The following is a description of a gene set: studied in species Homo sapiens Human Gene Set: GOBP_CARDIAC_CHAMBER_MORPHOGENESIS The process in which a cardiac chamber is generated and organized. A cardiac chamber is an enclosed cavity within the heart., and this is the list of marker genes: MIR17HG, GATA3, FOXC1, FZD2, MED1, NSD2, NRP1 (NCBI Gene Id 8829), RYR2, CPE (carboxypeptidase E), PROX1, FOXH1, WNT2, WNT11, TBX1, VANGL2, MIR1-1 (NCBI Gene Id 406904), MKS1, UBE4B, MDM2, BMP5 (NCBI Gene Id 653), TBX3, RBPJ, MESP1, CHD7, EVA1A, ZFPM2, DHRS3, PARVA, RARB, NOTCH2, COL11A1, MYL2, MSX2, SFRP2, BMP4, SOX11, NOG, HEY1, CAV3, NOS3, ADAMTS19, FGF8, TBX2, TGFB2, CCN1, TPM1, JAG1, APLNR, HEY2, NRG1, MYH6, ID2, BMPR1A, FOXF1, POU4F1, TNNI1, BMP2, SMAD6, GRHL2, NAGLU (N-acetyl-alpha-glucosaminidase), ROBO1, PTCD2, HAND2, TNNI3, SLIT3, MYH7, SRF, MYL3, RBP4, TNNT2, ENG, DNAH11, SMO, GATA4, ADAMTS1, FOXC2, DSP, PKP2, SEMA3C, HAND1, SOX4, TGFBR3 (transforming growth factor beta receptor 3), PITX2, ROBO2, FGFR2, GSK3A, PPP1R13L, ZFPM1 (NCBI Gene Id 161884), GATA6, SMAD7, CITED2, EGLN1, RBM15, ADPRHL1, SMARCD3, MEF2C, OVOL2, FGFRL1, ACVR1, TP53, SMAD4, SAV1, HEYL, TBX20, HIF1A, SLIT2, BMP7, SHOX2, NPY5R, ADGRG6, NPY2R, TBX5, HES1, NOTCH1, GJA5, TGFB1, TNNC1, TGFBR2, NKX2-5, FHL2, EDNRA, TEK, NRP2, SOS1, ISL1, MYBPC3, BMP10, RARA, BMPR2, HEG1, DLL4, FKBP1A, LRP2 (LDL receptor related protein 2), FZD1, TGFBR1